Given this list of marker genes Slc4a8, Ap1b1, Ap1s1, Ap1g1, Ap1m2, here is a description of the gene set: species: Mus musculus Mouse Gene Set: GOBP_BASOLATERAL_PROTEIN_SECRETION The controlled release of proteins from a cell at the sides which interface adjacent cells and near the base.